The following is a description of a gene set: Functions in the initiation of ribosome-mediated translation of mRNA into a polypeptide. Human Gene Set: GOMF_TRANSLATION_INITIATION_FACTOR_ACTIVITY species: Homo sapiens, and this is the list of marker genes: EIF2S1, MTIF3, EIF3I, EIF5, EIF3M, EIF2S3, EIF3B, EIF4G3, EIF3D, EIF4G1, EIF4E2, EIF3H, EIF2B2, COPS5, EIF2B4, EIF3E, EIF4G2, EIF1B, EIF1AD, EIF3F, EIF5B, EIF3K, EIF2B5, EIF3CL, EIF2S3B, EIF3J, EIF4E, EIF1AX, EIF1AY, DENR, EIF3A, MCTS1, MTIF2, EIF4A2, EIF4E1B, EIF6, EIF2A, EIF2B1, EIF3L, EIF3C, EIF1, EIF4B, EIF4H, EIF2D, EIF2B3, EIF2S2, AGO2, EIF3G, EIF4E3, DHX29, EIF4A1